Given this list of marker genes PPCDC, SYT9, UBE3B, TTC23L, SPTY2D1, MPZL2, SPRY3 (sprouty RTK signaling antagonist 3, NCBI Gene Id 253479), SLC45A4, ISX, TRANK1, SMAD3, SH3TC2, PDE1B, GLP1R, RCL1, METTL9, TM4SF19, CACNA2D2, GPATCH2L, SOS2, BOK, IFNLR1, MTCL2, DCUN1D5, AGK, GARRE1, TAF5, KLHL18, PRELP, MKNK2, TCFL5, AP2M1, TMEM141, ARHGEF12, URM1, ANKRD1, PROCR, TLK2 (NCBI Gene Id 11011), GLRA3, PLCE1, JMJD4, MAPK9, RBPJ, MKRN1, PITPNC1, ABHD11, GLCCI1, DAAM2, RNF44, PNOC, ALG9, UBE2D3, CELF5, RNF222, C1orf43, VXN, C2CD2L, EFNB1, GNB4, PLEKHG7, UBN2, RAB23, SFMBT1, RAB27B, NFIC (nuclear factor I C), CLOCK, HIPK3, PPM1F, RAB8B, XPNPEP1, ATG13, PPP1R12B, DPH3, WIPF2, PDCD2, NANOS1, CA10, PREX1, IFNAR2, UNC119B, ASAP1, FRMD4A, PLS3, MED1, CENPJ, SRD5A3, PPP1R13B, GNG7, FHL1, TYRO3, GAL3ST3, DAG1, FBXW7, LETM2, GPR55, here is a description of the gene set: Genes predicted to be targets of miRBase v22 microRNA hsa-miR-6765-3p in miRDB v6.0 with MirTarget v4 prediction scores > 80 (high confidence targets). Human Gene Set: MIR6765_3P from publication Chen Y, Wang X (PMID 31504780) species: Homo sapiens